The following is a description of a gene set: studied in species Homo sapiens Reactome Pathway: Germ layer formation at gastrulation Due to ethical considerations, most research on mammalian gastrulation has been performed on mouse embryos. Therefore most of the reactions described in this section are the results of research in mouse embryos. Significant research has also been performed on non-human primates such as cynomolgus monkeys (Macaca fascicularis). More recently, human gastrula-like cell assemblages ("gastruloids") generated from pluripotent stem cells have been developed and are now being compared with mouse embryos.<br>At the beginning of gastrulation in the mouse, the primitive streak forms in a region of BMP, WNT, FGF, and NODAL signaling. In the mouse embryo, NODAL is expressed throughout the epiblast before anterior-posterior axis induction and is required for pluripotency. NODAL signaling is restricted to the posterior side of the embryo by the secretion of NODAL and WNT antagonists (CER1, LEFTY1) from the anterior visceral endoderm (AVE). In human embryonic stem cells (hESCs) NODAL is also crucial for maintenance of pluripotency. In mouse embryos, NODAL and WNT3 are required for formation of the primitive streak and NODAL expression subsequently becomes restricted to the node at the anterior end of the primitive streak. Pro-NODAL secreted by the epiblast in response to BMP4 signalling from the extraembryonic ectoderm is converted to mature NODAL by furin (PCSK3) secreted from the extraembryonic ectoderm. NODAL maintains BMP4 expression in the extraembryonic ectoderm which then activates WNT3 in the posterior epiblast. WNT signaling, in turn, amplifies NODAL expression. The order of events in this signaling cascade may be different in human embryos due to differences in early embryo architecture.<br>NODAL, BMP, and WNT show similar effects on human 2D gastruloids. Mesoderm and definitive endoderm progenitors appear to be already separate and distinct in the primitive streak, therefore bipotential mesendoderm progenitors may be transitory if they exist. This is an area of ongoing research.<br>Mesoderm is formed by an epithelial-mesenchymal transition that produces an ingression of cells through the primitive streak. Endoderm does not show a complete epithelial-mesenchymal transition and instead forms by cell plasticity (a partial epithelial-mesenchymal transition in which both E-cadherin and N-Cadherin are expressed) (inferred from mouse embryos in Scheibner et al. 2021). However, in mouse embryos endoderm progenitors still ingress through the anterior region of the primitive streak, migrate with mesoderm cells, and eventually integrate into the visceral endoderm layer to give rise to the definitive endoderm.<br>Specific types of mesoderm are formed sequentially according to the time and position of ingression of cells through the primitive streak. This patterning is caused by gradients of NODAL, WNT, and BMP signaling that activate transcriptional programs in the mesoderm progenitors.<br>T-box transcription factor T (TBXT, T, Brachyury) and Eomesodermin (EOMES) are two of the first transcription factors expressed in mesoderm and endoderm progenitors in the primitive streak. The two factors combined are required for formation of all mesoderm and endoderm.<br>TBXT is activated by WNT signaling (via beta-catenin acting with LEF1 or TCF1) and BMP4 and is expressed in mesodermal and axial mesodermal progenitors and in the primitive streak during gastrulation, later becoming localized to the notochord and tailbud. TBXT is an early marker of mesodermal differentiation and is often used in studies of embryonic stem cells. In hESCs TBXT is expressed in both mesodermal and endodermal progenitors, it regulates different sets of target genes depending on the signaling environment.<br>Expression of EOMES is activated by NODAL via SMAD2 and SMAD3 and is observed in the posterior epiblast prior to formation of the primitive streak and in mesoderm and endoderm progenitors during the first day of gastrulation. EOMES in combination with SMAD2,3 is crucial for the activation of definitive endoderm genes. TBXT and EOMES generally activate expression of mesoderm genes and repress expression of genes associated with pluripotency such as SOX2 and NANOG.<br>Some transcription factors are particularly important for regulating gastrulation and are also used as markers for particular stages and morphological features. For example, Goosecoid (GSC) expression marks the onset of gastrulation, is first observed in the primitive streak, and becomes localized to the anterior end of the primitive streak and then the axial mesoderm. SMAD2 and SMAD3 activated by NODAL are recruited to the GSC promoter by FOXH1, which is already located at the promoter. MIXL1 also binds the GSC promoter and activates expression. In mice, GSC is a regulator of head development.<br>MIXL1 is required for formation of both mesoderm and definitive endoderm and is expressed early throughout the primitive streak and in nascent mesoderm cells exiting the streak. Expression of MIXL1 is mediated downstream by NODAL through SMAD2 and SMAD3 binding to the promoter of MIXL1. EOMES also plays a direct role in activating MIXL1 and GSC expression in hESCs and in mouse embryos..<br>Developing mesoderm becomes specified by expression of transcription factors such as MESP1, a marker of cardiac progenitors. part of: Gastrulation, and this is the list of marker genes: FOXH1, TBXT, LEF1, TRIM33, TBPL2, BMP4, POU5F1, SMAD4, SMAD2, GSC, EOMES, NANOG, TCF7, MIXL1, SMAD3, CTNNB1 (NCBI Gene Id 1499), SOX2